The following is a description of a gene set: Genes positively differentially expressed in cell type: CD4+ T cell upon treatment with cytokine: IL-34 in mouse lymph nodes in vivo. Cytokines mediate cell-cell communication in the immune system and represent important therapeutic targets. A myriad of studies have highlighted their central role in immune function, yet we lack a global view of the cellular responses of each immune cell type to each cytokine. To address this gap, the authors created the Immune Dictionary, a compendium of single-cell transcriptomic profiles of more than 17 immune cell types in response to each of 86 cytokines (>1,400 cytokine-cell type combinations) in mouse lymph nodes in vivo. A cytokine-centric view of the dictionary revealed that most cytokines induce highly cell-type-specific responses. For example, the inflammatory cytokine interleukin-1β induces distinct gene programmes in almost every cell type. A cell-type-centric view of the dictionary identified more than 66 cytokine-driven cellular polarization states across immune cell types, including previously uncharacterized states such as an interleukin-18-induced polyfunctional natural killer cell state. Mouse Gene Set: CUI_T_CELL_CD4_IL34_RESPONSE_UP species: Mus musculus from publication Cui A, Huang T, Li S, Ma A, Pérez JL, Sander C, Keskin DB, Wu CJ, Fraenkel E, Hacohen N (PMID 38057668), and this is the list of marker genes: Pdia3, Ly6c1, Ly6e, Ly6a, Bst2